The following is a description of a gene set: from publication Zheng S, Papalexi E, Butler A, Stephenson W, Satija R (PMID 29545397) Human Gene Set: ZHENG_CORD_BLOOD_C9_GRANULOCYTE_MACROPHAGE_PROGENITOR studied in species Homo sapiens, and this is the list of marker genes: GADD45GIP1, IGFBP7, C1QTNF4, C9orf78, ANP32B, STMN1, CALR (calreticulin), CENPF, TARS1, PTGES3, IRF8, IGLL1, NUCB2, PTMA, KDM5A, CFL1, NAP1L1, MT-ND4, KRR1, SAT1 (spermidine/spermine N1-acetyltransferase 1), DNAJC1, TBCA, ACTG1, HMGN5, SERF2, EIF3A, NCL, RB1CC1, SLK, HNRNPU, RAB32, PRPF40A, PLEK, H3-3B, CD44, LGALS1, HNRNPA1 (NCBI Gene Id 780920), SELL, PFN1, SF3B2, DSTN, MPO, HSPD1, ATP2B1 (ATPase plasma membrane Ca2+ transporting 1), CANX (NCBI Gene Id 821), BIRC5, LRRFIP1, LPAR6 (lysophosphatidic acid receptor 6), PIM3, GSTP1, HSP90AA1, H1-10, MKI67, BCL11A, ENO1, HNRNPM, HMGN2, PSMA7, ITM2C, CD99, B2M (beta-2-microglobulin), SMIM24, MAP3K2, TNFSF13B, PRR11, S100A10, ARID4A, MACROH2A1, RTN4, TAGLN2, GYPC, HGF, TUBA1B, HDGF, CP, LYZ, LCP1, PEBP1, ANXA1 (annexin A1), ATP5F1B, TMSB10, GAPDH, YY1, ZFP36L2, CALM1, PA2G4, CLEC11A, HLA-B (NCBI Gene Id 730410), HSP90B1, VAMP8, VIM, NIBAN1, HLA-A, NUCKS1, TPM3, AZU1 (NCBI Gene Id 566), TPM4, SET, RBM17, PIK3R1